The following is a description of a gene set: from publication Chen Y, Wang X (PMID 31504780) Genes predicted to be targets of miRBase v22 microRNA mmu_miR_423_5p in miRDB v6.0 with MirTarget v4 prediction scores > 80 (high confidence targets). species: Mus musculus Mouse Gene Set: MIR_423_5P, and this is the list of marker genes: Foxp4, Map1lc3a, Chga, Rell2, Mavs (NCBI Gene Id 228607), Arhgef4, Numbl, Rab40c, Grhl2, Celsr2, Laptm5, Golph3, Dscam, Snph, Enc1, Srl, Chd3, Cxcl14, Ucn3 (NCBI Gene Id 83428), Zdhhc9, Pip5k1c, Odc1, Dlk1, Sez6, Rnf214, Opa3, Clec16a, Cables2, Shank1, Ypel1, Sox12, Cp, Glis2, Erf (Ets2 repressor factor), Mtcl2, Gjb1, Hddc3, Ttll4, Slc20a2, Mras, Smarcc2, Spryd3, Lypd11, Faf2, Cyp4f39, Cd177, Yars2, Eng, Lypd10, Sdc2, Pak3, Myh14, Eri3, Tmem150a, Samd4b, St6galnac6, Clip2 (NCBI Gene Id 269713), Dlgap3, Acsf2 (NCBI Gene Id 264895), Fam222b, Abcc5, Krt88, Gns (NCBI Gene Id 97675), Clcn4, Zbtb24, Acap3, Csf1, Atp8b2, Upk3b, Trappc14, Tfdp1, Zwint, Cops4, Akap13, Zmym4, Septin9, Syp, Rab11b, Fndc11, Gpatch8, Adar, Thy1, Kcnq2, Cers2, Selp, Nrsn2, Ganab, Micall1, Agap3, Mien1 (NCBI Gene Id 66428, migration and invasion enhancer 1), Ark2c, Pianp, Zfp609, Hbp1, Bap1, Fam3a, Clk2, Srsf1, Lasp1, Arid3b, Nav1